Given this list of marker genes NOG, POR (cytochrome p450 oxidoreductase), GDF5, PTDSS1, WNT7A, FGFR1, FGFR2, MUSK, here is a description of the gene set: Human Gene Set: HP_ELBOW_ANKYLOSIS studied in species Homo sapiens Elbow ankylosis